Given this list of marker genes Inpp4b, Wnk1 (NCBI Gene Id 406236), Mapk14, Hnf4a, Hsp90ab1, Efcab7, Shh, Chp1, Psen1, Txn1, Nfkbia, Flna, Cwh43, Thoc5, Fermt1, Sumo1, Bag3, Park7, Ect2, Apod, Xpo1, Tek, Bmp4, Rbm10, Ipo5, Akap5, Rab23, Anp32b, Ywhab, Nolc1, Trim28, Jup, Nsun2, Dmap1, Rapgef3, Sirt7, Hyal2, Tardbp, Ifi27, Cdk5, Ptpn14, Peg12, Ep300, Angpt1, Ddx39a, Hdac3, Chp2 (calcineurin-like EF hand protein 2), Ufm1, Lep, Zc3h12a, Hsp90aa1, Cdkn2a, Cpsf6, Ptpn11, Fam76b, Ctdspl2, Nedd4, Frat2, Khdrbs1, Wipf1, Tgfb1, Ywhae, Frat1, Ptgs2, Prkcq, Nup153, Mdfic, Akap8l, Ran, Jak2, Ptpn22, Nup214, Gli3, Zpr1, Tmem53, Mapk1, Uaca, Gper1, Setd2, Prkd1, Nup58 (nucleoporin 58), Cdh1, Pik3r2 (phosphoinositide-3-kinase regulatory subunit 2), Xbp1, Rbm22, Pik3r1, Il6, Rangap1, Mavs, Ppm1a, Cdk1, Smo, Akap1, Ubr5, Pkig, Gbp4, Ppp1r12a, Agtr2, Ptpn5, Tpr, Supt6, Brca1, Ppp1cc (NCBI Gene Id 627816), Sp100, Thoc2, Sfn, Ncbp2, Prpf4b, Chchd4, Pkia, Ei24, Gsk3b, Rbm4, Nup54, Uhmk1, Zic1, Nup62, Hm629797, Prkaca, Camk4, Hcls1, Ier3, Bard1, Nrde2, Mdm2, Nutf2-ps1, Cd36 (NCBI Gene Id 12491), Riok2, Gas6, Alkbh5, Dhx9, Iws1, Prkcd, Nf1, Nutf2, Camk1, Epm2a, Cabp1, Tnfrsf1a (tumor necrosis factor receptor superfamily, member 1a, NCBI Gene Id 21937), Sirt6, Ifng, Emd, Xpo4, here is a description of the gene set: species: Mus musculus Mouse Gene Set: GOBP_REGULATION_OF_NUCLEOCYTOPLASMIC_TRANSPORT Any process that modulates the frequency, rate or extent of the directed movement of substances between the nucleus and the cytoplasm.